Given this list of marker genes SACS, HTR2A, SRD5A2 (NCBI Gene Id 6716), SPTBN4, PENK, ASS1, SRD5A1, here is a description of the gene set: studied in species Homo sapiens A neuron projection that is found in unipolar neurons and corresponds to the region between the cell body and the point at which the single projection branches. Human Gene Set: GOCC_CELL_BODY_FIBER